Given this list of marker genes SPTBN2, JAM3, MARVELD2, CLDN19, CNTNAP2, CNTNAP1, KCNA2, SIRT2, NFASC, here is a description of the gene set: A highly specialized cell-cell junction found in vertebrates, which forms between a neuron and a glial cell, and has structural similarity to Drosophila septate junctions. It flanks the node of Ranvier in myelinated nerve and electrically isolates the myelinated from unmyelinated nerve segments and physically separates the voltage-gated sodium channels at the node from the cluster of potassium channels underneath the myelin sheath. species: Homo sapiens Human Gene Set: GOCC_PARANODAL_JUNCTION